The following is a description of a gene set: The series of molecular signals initiated by the binding of the cytokine granulocyte macrophage colony-stimulating factor (GM-CSF) to its receptor on the surface of a target cell, and ending with the regulation of a downstream cellular process, e.g. transcription. GM-CSF binds to a heterodimer receptor (CSF2R) consisting of an alpha ligand-binding subunit, and a common beta subunit that is shared with other cytokine receptors. Mouse Gene Set: GOBP_GRANULOCYTE_MACROPHAGE_COLONY_STIMULATING_FACTOR_SIGNALING_PATHWAY studied in species Mus musculus, and this is the list of marker genes: Jak2, Csf2, Csf2ra, Csf2rb2, Csf2rb